The following is a description of a gene set: Mouse Gene Set: chr4B3 studied in species Mus musculus, and this is the list of marker genes: Gm12516, Rpsa-ps11, Gm21286, Tmem245, Mup-ps7, Mup-ps26, Klf4, Gm12538, Mup13, Mup-ps23, Gm12536, Mup21 (major urinary protein 21), Slc46a2, Gm12514 (predicted gene 12514), Zkscan16 (zinc finger with KRAB and SCAN domains 16), Txndc8, Mup22, Gm12518, Pole3, Mup-ps11, Mup11, Epb41l4b, Ptbp3, Hdhd3, Gm22300, Gm12527, Zfp37, Gm12512, Gm12537, Gm12539, 4933430I17Rik, Mup1, Ptpn3 (NCBI Gene Id 545622), Actl7b, Mup14, Mir3095, Mup-ps4, Mup9, Gm25391, Txn1, Alad, Mup-ps1, Mup5, Ptgr1, Mup19, Mup-ps5, Mup-ps17, Mup-ps15, Mup-ps21, Mir455, Ambp, Mup10, Mup-ps12, Gm11210, Snx30, Mup-ps10, Rad23b, Gm26138, Mup3, Mup6, Gm12513, Mup-ps14, Gm12909, Ugcg (UDP-glucose ceramide glucosyltransferase), 2310081O03Rik, Gm25419 (NCBI Gene Id 115490083), Gm12526, Gm12579, Mup8, Dnajc25, Gm11211, Mup-ps9, D630039A03Rik, Fkbp15, Slc31a2, Orm1, Mup15, Gm12508, Lpar1, Gm12530, Mup-ps2, Gm13773, Mup-ps28, Gm12580, Zfp618, Susd1, Or2k2, Elp1, Slc31a1, Mup17, Mup18, Frrs1l, Shoc1, Mup-ps16, Mup-ps13, Gm12542, Gm12505, Wdr31, Gm24117, Abitram, E130308A19Rik, Inip, Mup20, Gm11212, Gm26144, Col27a1, Gm12543, Pakap, Prpf4, Musk, Svep1 (NCBI Gene Id 80647), Mup-ps6, 1700042G15Rik, Mup-ps24, Mup4, Gng10, Hsdl2, Gm12596 (predicted gene 12596), Actl7a, Mup-ps18, Mir32, Gm22150, Gm12577, Orm3, Mup-ps3, Rnf183, Bspry, Cdc26, Kif12 (NCBI Gene Id 16552), Mup-ps19, Ecpas (Ecm29 proteasome adaptor and scaffold), Gm12519, Ctnnal1, Mup2, Orm2, Mup7, Mup12 (NCBI Gene Id 100039054), Rgs3, Mup-ps29, Mup16, Gm25053, Mup-ps8